The following is a description of a gene set: Human Gene Set: GOBP_RRNA_MODIFICATION The covalent alteration of one or more nucleotides within an rRNA molecule to produce an rRNA molecule with a sequence that differs from that coded genetically. studied in species Homo sapiens, and this is the list of marker genes: MRM1, TSR3, MRM3, TFB2M, RPUSD4, NOP10, FBL, RPUSD1 (NCBI Gene Id 64723), DIMT1, METTL25B, NHP2, NSUN3 (NOP2/Sun RNA methyltransferase 3), FTSJ3, TRMT2B, BUD23, TRMT112, TFB1M, METTL5, NAT10, MRM2, RPUSD2, FDXACB1, ZCCHC4, METTL16, GAR1, FBLL1, NAF1, EMG1, METTL15, TRMT61B, NOP2, NSUN5, NSUN4, METTL15P1 (NCBI Gene Id 401095), DKC1, SPOUT1